The following is a description of a gene set: Mouse Gene Set: GOBP_RNA_IMPORT_INTO_MITOCHONDRION species: Mus musculus The process in which a rRNA, ribosomal ribonucleic acid, is transported from the cytosol into the mitochondrial matrix., and this is the list of marker genes: Mrpl18, Tomm20l, Tomm20, Pnpt1, Tst